The following is a description of a gene set: Genes up-regulated in U87MG cells (glioblastoma multiforme) after knockdown of PRKCI by RNAi. species: Homo sapiens Glioblastoma multiforme is an aggressive form of brain cancer that responds poorly to chemotherapy and is generally incurable. The basis for the poor response of this cancer to chemotherapy is not well understood. The atypical protein kinases C (PKCiota and PKCzeta) have previously been implicated in leukaemia cell chemoresistance. To assess the role of atypical PKC in glioblastoma cell chemoresistance, RNA interference was used to deplete human glioblastoma cells of PKCiota. Transfection of cells with either of two different RNA duplexes specific for PKCiota caused a partial sensitisation to cell death induced by the chemotherapy agent cisplatin. To screen for possible mechanisms for PKCiota-mediated chemoresistance, microarray analysis of gene expression was performed on RNA from glioblastoma cells that were either untreated or depleted of PKCiota. This identified sets of genes that were regulated either positively or negatively by PKCiota. Within the set of genes that were negatively regulated by PKCiota, the function of the gene coding for GMFbeta, an enhancer of p38 mitogen-activated protein kinase (MAP kinase) signaling, was investigated further, as the p38 MAP kinase pathway has been previously identified as a key mediator of cisplatin cytotoxicity. The expression of both GMFbeta mRNA and protein increased upon PKCiota depletion, and this was accompanied by an increase in cisplatin-activated p38 MAP kinase signaling. Transient overexpression of GMFbeta increased cisplatin-activated p38 MAP kinase signaling and also sensitised cells to cisplatin cytotoxicity. The increase in cisplatin cytotoxicity seen with PKCiota depletion was blocked by the p38 MAP kinase inhibitor SKF86002. These data show that PKCiota can confer partial resistance to cisplatin in glioblastoma cells by suppressing GMFbeta-mediated enhancement of p38 MAP kinase signaling. from publication Baldwin RM, Garratt-Lalonde M, Parolin DA, Krzyzanowski PM, Andrade MA, Lorimer IA (PMID 16331246) Human Gene Set: BALDWIN_PRKCI_TARGETS_UP, and this is the list of marker genes: TRIM56, MTCL1, GMFB, PAK2, CBX6, TGOLN2, TSPAN6 (NCBI Gene Id 7105), SLK, IFITM1, TFDP2 (transcription factor Dp-2), EIF1AX, TDO2, ZBTB20, PALS1, ATP2B4, TMEM106C, SELENOP, NUDT3, EIF4EBP2, AQP9, FOSL2, SLC35A5, OXTR, RHOB, ATP6V1G1, NEK9, CCN3, CGB3, GPRC5A, HFE, MPDZ, SLC4A7, SDC2, CCN5 (NCBI Gene Id 8839), SLC11A2, ADA, MAZ, SEPTIN11, TRIB2, MEF2A